Given this list of marker genes Slc12a1, Aqp9, Slc14a1, Pou3f3, Slc14a2, Aqp8, Aqp7, Umod, here is a description of the gene set: species: Mus musculus Mouse Gene Set: GOBP_UREA_TRANSMEMBRANE_TRANSPORT The process in which urea, the water-soluble compound H2N-CO-NH2, is transported from one side of a membrane to the other by means of some agent such as a transporter or pore.